Given this list of marker genes Ccdc32, Fcho2, Slc9b2, Fnbp1l (formin binding protein 1-like), Dgkd, Hip1r, Lmbrd1, Dll1, Ston1, Neu3, Aak1, Sgip1 (SH3-domain GRB2-like (endophilin) interacting protein 1), Gpr107, Gak, Inpp5f, Syt11, Unc119, Dnm1, Fchsd2, Itga4, Picalm, Smap1, Ap2a2, Bmp2k, Ubqln2, Itsn1, Ston2, Ush1g, Scyl2, Ap2a1, Sh3gl2, Ap2m1, Sh3gl3, Clta, Itsn2, Canx, Fcho1, Ap2s1, Dab2, Dnm2, Dnajc6, Cltb (NCBI Gene Id 74325), Siglec1, Wasl, Snap91, Ap2b1, Gas7, Tnk2, Magi2, Cltc, here is a description of the gene set: species: Mus musculus Mouse Gene Set: GOBP_CLATHRIN_DEPENDENT_ENDOCYTOSIS An endocytosis process that begins when material is taken up into clathrin-coated pits, which then pinch off to form clathrin-coated endocytic vesicles.